The following is a description of a gene set: Human Gene Set: HP_LOW_BACK_PAIN An unpleasant sensation characterized by physical discomfort (such as pricking, throbbing, or aching) localized to the lower back. Low back pain studied in species Homo sapiens, and this is the list of marker genes: MNX1, HLA-B (NCBI Gene Id 730410), STAT6, HGD, NGF, WRN, MEFV, WASHC5, HTRA1, AEBP1, ANXA11, NAB2 (NGFI-A binding protein 2), ALDH18A1, SPAST, TBX6